The following is a description of a gene set: Mouse Gene Set: GOBP_CELLULAR_RESPONSE_TO_GONADOTROPIN_STIMULUS Any process that results in a change in state or activity of a cell (in terms of movement, secretion, enzyme production, gene expression, etc.) as a result of a gonadotropin stimulus. studied in species Mus musculus, and this is the list of marker genes: Epha8, Epha5, Akr1c18, Ccna2, Cyp1b1, Efna5, Gata4, Inhba (NCBI Gene Id 16323), Gata6 (GATA binding protein 6), Edn1, Lhcgr, Star, Nsmf, Gclc, Epha3, Gata1, Fshr, Pde4d, Notch1, Wt1, Ednra, Pax8, Ppargc1a, Gclm